Given this list of marker genes DHX16, LMNB2, SNRPA1, ATP5PF, CBFB, SSBP1, G3BP2, DDX1, CDC123, RAD1, PRRC2C, IRAK1, ILF3, SF3B2, SDHB, SNRPD3, PDIA6, MPV17, H2AZ1, NDUFC1, NSDHL, ATP5PO, MAPRE1, SRSF1, HCCS, UCHL3, MOGS, TRIM28, MAGOH, EID1, HSPA9, CYCS, CDK4, CCT8, PPID, TARDBP, LAGE3, UBE2N, SET, ACOT7, DDX19A, CCT5, NDUFV1, DR1, FEN1, SLBP, DNAJC9, HDDC2, BUB3, BAZ1B, R3HDM1, KHSRP, AKR7A2 (NCBI Gene Id 94395), SOD1, VPS26A, VDAC1, RBM14, NUP205, UTP3, KIF11, SRSF9, PARK7, RMND5A, MTDH, PTPN11, MCM6, NDUFB3, VAMP7, MRFAP1L1, ACOT13, ANP32A (acidic nuclear phosphoprotein 32 family member A), VBP1, NHP2, DDX19B, GMPS, RAD23A, VDAC2, RFC2, LSM4, CSNK2B (NCBI Gene Id 257616), NDUFS6, NAA10, PPM1G, NDC80, CHERP, NDUFS4, THAP11, NDUFS8, NDUFV2, KIDINS220, HAT1, PMEL, LARP1, UPF3A, SCAMP3, EIF3B, PTGES3, IFRD1, SMC3, SLC1A5, MFAP1, XPOT, NDUFS3, HNRNPR, ATP5MC3, TOMM70, NARS1, TARS1, here is a description of the gene set: studied in species Homo sapiens Neighborhood of PTPN11 protein tyrosine phosphatase, non-receptor type 11 (Noonan syndrome 1) in the MORF expression compendium Human Gene Set: MORF_PTPN11 Neighborhood of PTPN11